Given this list of marker genes GDAP2, SYNJ1, VCP, MFSD8, CACNB4, GFAP, LRP12, PSEN2, RAX2, CSF1R (colony stimulating factor 1 receptor), ATXN3, POLG, LBR, EPCAM, XRCC1, POLG2, NAGA, MME (NCBI Gene Id 4311), TMEM126B, PSEN1, ATP7B, CAV3, CHCHD10, KCNJ11, MYH7, VAPB, MAPT, SAMD9L, PRKN, SLC22A12, SCN3B, DNM1L, PTEN, PRPH2, H6PD, CLCN2, CHRNA2, ANXA11 (NCBI Gene Id 311), CYP27A1, PRNP, HSPB1, CFH, KCNA5, here is a description of the gene set: Late young adult onset studied in species Homo sapiens Human Gene Set: HP_LATE_YOUNG_ADULT_ONSET Onset of disease at an age of greater than or equal to 25 to under 40 years.